Given this list of marker genes SCIMP, PSTPIP1, PIP5K1B, SELPLG, ICAM2, SPN, EZR, BST1, DNM2, MSN, FLOT1, PRICKLE1, PIP5K1C, MYH9, FLOT2, here is a description of the gene set: Human Gene Set: GOCC_CELL_TRAILING_EDGE The area of a motile cell opposite to the direction of movement. studied in species Homo sapiens